The following is a description of a gene set: Human Gene Set: CAO_BLOOD_FLUMIST_AGE_05_14YO_7DY_UP from publication Cao RG, Suarez NM, Obermoser G, Lopez SM, Flano E, Mertz SE, Albrecht RA, García-Sastre A, Mejias A, Xu H, Qin H, Blankenship D, Palucka K, Pascual V, Ramilo O (PMID 24495909) Genes up-regulated in blood 7d vs 0d in children (0.5-14y) after exposure to FluMist, time point 7D. Comment: ~80% of cohort were white, ~50/50 Female:male BACKGROUND: Live attenuated influenza vaccine (LAIV) and trivalent inactivated influenza vaccine (TIV) are effective for prevention of influenza virus infection in children, but the mechanisms associated with protection are not well defined. METHODS: We analyzed the differences in B-cell responses and transcriptional profiles in children aged 6 months to 14 years immunized with these 2 vaccines. RESULTS: LAIV elicited a significant increase in naive, memory, and transitional B cells on day 30 after vaccination, whereas TIV elicited an increased number of plasmablasts on day 7. Antibody titers against the 3 vaccine strains (H1N1, H3N2, and B) were significantly higher in the TIV group and correlated with number of antibody-secreting cells. Both vaccines induced overexpression of interferon (IFN)-signaling genes but with different kinetics. TIV induced expression of IFN genes on day 1 after vaccination in all age groups, and LAIV induced expression of IFN genes on day 7 after vaccination but only in children < 5 years old. IFN-related genes overexpressed in both vaccinated groups correlated with H3N2 antibody titers. CONCLUSIONS: These results suggest that LAIV and TIV induced significantly different B-cell responses in vaccinated children. Early induction of IFN appears to be important for development of antibody responses. species: Homo sapiens, and this is the list of marker genes: BCAS2, ICA1, C11orf24, OAS2, DSCC1, FASLG, MASTL